Given this list of marker genes HDLBP, APOA1, SCARB1, CUBN, AMN, here is a description of the gene set: Human Gene Set: REACTOME_HDL_CLEARANCE studied in species Homo sapiens HDL clearance